The following is a description of a gene set: from publication Abbas AR, Baldwin D, Ma Y, Ouyang W, Gurney A, Martin F, Fong S, van Lookeren Campagne M, Godowski P, Williams PM, Chan AC, Clark HF (PMID 15789058) Genes down-regulated in comparison of memory IgG IgA B cells versus blood plasma cells. species: Homo sapiens Immune cell-specific expression is one indication of the importance of a gene's role in the immune response. In order to identify such patterns, we set out to broadly profile gene expression in a variety of immune cells. Human Gene Set: GSE22886_IGG_IGA_MEMORY_BCELL_VS_BLOOD_PLASMA_CELL_DN, and this is the list of marker genes: R3HCC1, USP5, CLEC2B, H1-2, NUP42, ALG9, MOGS, FBXO5, IGKV1D-13, CHPF (chondroitin polymerizing factor), IBTK, ATF5, QPCT, CCDC88C, SLC25A4, EIF2B3 (eukaryotic translation initiation factor 2B subunit gamma), ARSA, SEPTIN10, GTF3C2, TAPBPL, HMCES, ABHD14A, UFSP2, EMC9, NEK4, WDR45, CCDC51, DNM1L, BLMH, ABCB9, NTAQ1, EIF1AY, CCR10, HSD17B8, XPNPEP1, RARS1, API5, LIME1, TBL2, LGALS3, PPIP5K2, PRDM1, TUT7 (NCBI Gene Id 79670), EDC4, GSTZ1, NXPE3, ISG15, IGKV3-20, UGDH, ODR4, PDHX, NCAPG, AVEN, FNDC3B, BAK1, SLC1A4, CDC73, VPS54, GFPT1, CALM3, TOP6BL (NCBI Gene Id 79703), FOCAD, TMF1 (NCBI Gene Id 7110), TM9SF1, ADIPOR1, CREB3L2, CD27, H2BC6, CTBS, RBM47 (RNA binding motif protein 47), SLC33A1, SERF2, NDUFA7, MRPL28, GPN2, SSR3, CASP3, GLT8D1, GNS, GGCX, TST, MRPL16, CD14, BIRC2, PTPN7, CHST12, GPAA1, SERINC3, CHST15, DNAJC1, WIPI1, GADD45A, HERPUD1, CLPB, SELPLG, PLOD1, CYREN, RALY, BAG3, RBPJ, ERAP1, RGCC, CLINT1, IFI35, AURKA, AQP3, DEF8, CLASP2, NSF, MRPS34, LAP3, TM9SF4, ADA (NCBI Gene Id 100), MAGT1, MLEC, PDK1, SPAG5, GOLPH3L, ANKHD1 (ankyrin repeat and KH domain containing 1), STAM, UGGT1, MXD4, IFNAR2, ARPC1A, PIGK, BTN2A2, RCBTB2, TRIB1, PUDP, SLC39A7, PARP2, COMT, ATP6V1C1, DDX49, NFYC, TFG (trafficking from ER to golgi regulator), BHLHE41, ANTKMT, ST6GALNAC4, NAA10, ATXN1, RCC1L, LRPAP1, MTX2, TRIP12, SPATS2, DNPH1, GPRC5D, BPNT2, GET1, SS18, SEMA4A, WFS1, IGF1, IFT20, CYTH2, PCCB, SPTLC1, LRRC42, SEC24A, TMEM184B, RPAIN, LEPROTL1, TIMP2, TMX2, C1GALT1C1, ICAM4, INPP1, SLC50A1, PTRH2, P3H1, SPTSSA, H2BC9, CCNH, DICER1, LY6G6D, FNDC3A, SLC39A14, CADM1, ETNK1, RRBP1, CCPG1, GOT1, RCN1, ARFGAP3, ITFG1, GOLT1B, MAGED2, ADA2, DIPK1A, TTC38, HIBCH, FUT8, AGA, MRPS22, PGRMC2, TSG101, UFL1